The following is a description of a gene set: Human Gene Set: GOBP_REGULATION_OF_LONG_CHAIN_FATTY_ACID_IMPORT_INTO_CELL Any process that modulates the frequency, rate or extent of long-chain fatty acid import into a cell. studied in species Homo sapiens, and this is the list of marker genes: IRS2, AKT2, FABP3, AKT1, ACSL1, THBS1, EPRS1, ACSL5